The following is a description of a gene set: species: Homo sapiens Neolacto series sphingolipid metabolism Human Gene Set: WP_NEOLACTO_SERIES_SPHINGOLIPID_METABOLISM, and this is the list of marker genes: ST3GAL4, FUT2, FUCA1, NEU2, FUT1, NAGA, FUT5, B4GALT3, B4GALT4, B4GALT1, B3GNT5